Given this list of marker genes TCF3, PRKDC, POLB, LIG1, RAG2, LIG3, DCLRE1C, BCL11B, XRCC4, LIG4, LEF1, ATM, NHEJ1, YY1, HMGB1, RAG1, HMGB2, DCAF1, CYREN (NCBI Gene Id 78996), here is a description of the gene set: species: Homo sapiens The process in which immune receptor V, D, and J, or V and J gene segments, depending on the specific receptor, are recombined within a single locus utilizing the conserved heptamer and nonomer recombination signal sequences (RSS). Human Gene Set: GOBP_V_D_J_RECOMBINATION